Given this list of marker genes GTF2F1, ELOA, POLR2D, POLR2G, TCEA1, POLR2K, ELL, ELOA2, tat, CCNT1, SUPT5H, CTDP1, SUPT16H (SPT16 homolog, facilitates chromatin remodeling subunit), NELFA, NELFCD, POLR2A, POLR2B, POLR2H, ELOC, POLR2J, SSRP1, CDK9, POLR2I, POLR2F, NELFB, ELOB, POLR2C, POLR2L, GTF2F2, NELFE, SUPT4H1, POLR2E, here is a description of the gene set: part of: Transcription of the HIV genome After Pol II pauses by back tracking 2 -4 nuleotides on the HIV-1 template, elongation of the HIV-1 transcript resumes. studied in species Homo sapiens Reactome Pathway: Pausing and recovery of Tat-mediated HIV elongation